The following is a description of a gene set: from publication Fujii T, Kawahara A, Basaki Y, Hattori S, Nakashima K, Nakano K, Shirouzu K, Kohno K, Yanagawa T, Yamana H, Nishio K, Ono M, Kuwano M, Kage M (PMID 18316615) Genes up-regulated in MCF-7 cells (breast cancer) after knockdown of YBX1 by RNAi. In our present study, we examined whether nuclear localization of Y-box binding protein-1 (YB-1) is associated with the expression of epidermal growth factor receptors (EGFR), hormone receptors, and other molecules affecting breast cancer prognosis. The expression of nuclear YB-1, clinicopathologic findings, and molecular markers were immunohistochemically analyzed. The association of the expression of nuclear YB-1 and the molecular markers was examined in breast cancer cell lines using microarrays, quantitative real-time PCR, and Western blot analyses. Knockdown of YB-1 with siRNA significantly reduced EGFR, HER2, and ER alpha expression in ER alpha-positive, but not ER alpha-negative, breast cancer cell lines. Nuclear YB-1 expression was positively correlated with HER2 (P = 0.0153) and negatively correlated with ER alpha (P = 0.0122) and CXCR4 (P = 0.0166) in human breast cancer clinical specimens but was not correlated with EGFR expression. Nuclear YB-1 expression was an independent prognostic factor for overall (P = 0.0139) and progression-free (P = 0.0280) survival. In conclusion, nuclear YB-1 expression might be essential for the acquisition of malignant characteristics via HER2-Akt-dependent pathways in breast cancer patients. The nuclear localization of YB-1 could be an important therapeutic target against not only multidrug resistance but also tumor growth dependent on HER2 and ER alpha. Human Gene Set: FUJII_YBX1_TARGETS_UP studied in species Homo sapiens, and this is the list of marker genes: MAOB, SERHL2, SEMA6D, GPR87, SMIM5, PDK4, SYTL1, TINCR, PAM, SLC16A3, FAS, CLIC3, WARS1, GPER1, PRICKLE1, MVP, CAPG, ACTA2, CPNE4, CDKN1A, NR5A2, MBD2, SELENOP, S100A6, ULK1 (NCBI Gene Id 8408), CDC42SE2, NLRC5, MX2, DIAPH2, SULF1, LGALS9, CEACAM1, CCL5 (NCBI Gene Id 8147), TRIM22, PLAAT4, GIMAP2, MUC1, ASCL1, TRIB2, POF1B (NCBI Gene Id 79983), CFB, KLF11, EDIL3